The following is a description of a gene set: Mutational activation of ras genes is required for the onset and maintenance of different malignancies. Here we show, using a combination of molecular physiology, nutritional perturbations and transcriptional profiling, that full penetrance of phenotypes related to oncogenic Ras activation, including the shift of carbon metabolism towards fermentation and upregulation of key cell cycle regulators, is dependent upon glucose availability. These responses are induced by Ras activation, being specifically reverted by downregulation of the Ras pathway obtained through the expression of a dominant-negative Ras-specific guanine nucleotide exchange protein. Our data allow to link directly to ras activation the alteration in energy metabolism of cancer cells, their fragility towards glucose shortage and ensuing apoptotic death. studied in species Mus musculus Genes down-regulated in NIH3T3 cells (fibroblasts) transformed by activated KRAS vs those reverted to normal cells upon over-expression of a dominant negative form of CDC25. Mouse Gene Set: CHIARADONNA_NEOPLASTIC_TRANSFORMATION_KRAS_CDC25_DN from publication Chiaradonna F, Sacco E, Manzoni R, Giorgio M, Vanoni M, Alberghina L (PMID 16607279), and this is the list of marker genes: Cebpb, Maged1, Mgp, Loxl1, Emb, Igsf10, Btg3, Zfp36, Vcam1, Cdo1, Tmem176b (NCBI Gene Id 69098), Ccdc80 (coiled-coil domain containing 80), Stat3, Fos (NCBI Gene Id 14281), Adam23, Lxn, Saa3 (serum amyloid A 3), Crtap, Fgfr2, Cyp1b1, Ly6a, Il1r1, Pdk4, Dpep1, Vdr, Ddr1 (discoidin domain receptor family, member 1), Ltbp2, Cxcl5, Nsg1, Fas, Cxcl12, Ptgs2, Ap3s1, Tmem176a, Cxcl1, Il1rl1, Vegfd, Lama4, Nid1, Meg3, Pros1, Osmr (NCBI Gene Id 18414), Zfp36l2 (NCBI Gene Id 12193), Rnase4, Eif2ak4, Ptx3, Tnc, Slpi, Lox, Ccn5, Slc12a2, C3, Foxp1 (forkhead box P1), Il11ra1, Man2a1